The following is a description of a gene set: Human Gene Set: GOBP_PRIMARY_ALCOHOL_CATABOLIC_PROCESS studied in species Homo sapiens The chemical reactions and pathways resulting in the breakdown of primary alcohols. A primary alcohol is any alcohol in which a hydroxy group, -OH, is attached to a saturated carbon atom which has either three hydrogen atoms attached to it or only one other carbon atom and two hydrogen atoms attached to it., and this is the list of marker genes: ALDH1B1, ACSS2, SULT1A1, AKR1B10, SULT1E1, ACSS1, ALDH3B1, AKR1C3 (aldo-keto reductase family 1 member C3), SULT1A4, ALDH3B2, HAO1, SULT2A1, SULT1A3, SULT1B1, SULT1C4, SULT1A2, ALDH2